The following is a description of a gene set: The process whose specific outcome is the progression of the embryonic heart tube over time, from its formation to the mature structure. The heart tube forms as the heart rudiment from the heart field. studied in species Homo sapiens Human Gene Set: GOBP_EMBRYONIC_HEART_TUBE_DEVELOPMENT, and this is the list of marker genes: NOTCH2, MESP1, NOTCH1, HAND2, OVOL2, DVL1, SRF, WNT5A, CDC42, APELA, TRAF3IP1, NCKAP1, ARL13B, SOX17 (SRY-box transcription factor 17), CCDC39, ENG, MEF2C, IFT172, MEGF8, TBX2, VANGL2, FOXH1, HIF1A, SMAD3, CLUAP1, TMED2, STIL, ACVR1, PITX2, HAND1, CIMAP3, MKKS, NKX2-5, PKD2, BBS7, NOTO, CTNNB1, DNAAF1, EDNRA, TBX3, GATA4, DLL1, NODAL, FGF8, CITED2, PLXNA4, ECE1, TGFBR2, IFT52, FOXC1, MED1, C2CD3, TEAD2, SOX18, LBX1, IFT57, AHI1, DVL2, FOXC2, RYR2, TBX20, SUFU, MICAL2, NKX2-6, EDN1, NPHP3, NDRG4, BBS5, WNT3A, YAP1, GJA5, PSEN1, SMO, CCDC40 (NCBI Gene Id 55036), ZIC3, FOLR1, SHH, IHH, APLNR, MIB1, CCDC103, IFT122, HES1 (NCBI Gene Id 3280), ASB2, RNF207, SETDB2, FOXN4, GREB1L